The following is a description of a gene set: studied in species Homo sapiens Any process that results in a change in state or activity of a cell or an organism (in terms of movement, secretion, enzyme production, gene expression, etc.) as a result of a food stimulus; food is anything which, when taken into the body, serves to nourish or build up the tissues or to supply body heat. Human Gene Set: GOBP_RESPONSE_TO_FOOD, and this is the list of marker genes: COMT, PPARA, NPFF, OXT, AKT1, CLPSL1, SLC16A1 (NCBI Gene Id 6566), FBN1, PLEC, G6PC1, CARTPT, NENF, SREBF1, GHRL, LEP, UCN, SCNN1B, TRPA1 (NCBI Gene Id 8989), MPO, SLC25A25, CYP1A1, BCL10, GDF15, MKKS, GPR180, GFRAL, HSD11B2, GAST, GHRH, CLPSL2, G6PD, MT3, BBS2, GHR, MC4R, ETNPPL, NPY, CLPS, PRKCG, GPR82, GHSR, TMEM126B, ATN1, TMEM135, BBS4, SPX, CPS1